Given this list of marker genes Tac1, Tac2, Fez1, Kif3a, Rhot1, Caly, Trim46, Clxn (NCBI Gene Id 74659), Ttll6, Borcs5, Tppp2, Tex101, Defb37, Iqcf1, Lamp1, Cfap206, Tac4, Cyb5d1, Spinkl, Cfap43, Mecp2, Cnih2, Bbs2, Nefh, Or4m1, Eppin, Anxa5, Cfap69, Rgn, Bbs1, Adam7, Tacr1, Cfap298, Odad2, Dnaaf1, Hap1, Rsph4a, Cfap20, Map2, Defb1, Ccdc39, Tacr2, Rnase9, Gas2l2, Tacr3, Irgc, Dnah11, Mapt, Prdm14, Stk11, Kif9, Bbs4, Spag6l, Trim58, Dynlt2b, Ccdc65, Wfdc6b, Ccdc40, Ccr6, Rnase10, Mkks, Wfdc6a, Catsper1, Drc1, Cfap45, Ttc21b, here is a description of the gene set: Mouse Gene Set: GOBP_REGULATION_OF_MICROTUBULE_BASED_MOVEMENT studied in species Mus musculus Any process that modulates the rate, frequency, or extent of microtubule-based movement, the movement of organelles, other microtubules and other particles along microtubules, mediated by motor proteins.